Given this list of marker genes MLXIPL, GTF2IRD1, TMEM270, METTL27, RFC2, LDLRAP1 (low density lipoprotein receptor adaptor protein 1), RRAS2, GTF2I, LTBP1, FKBP6, ABCG8, FBLN5, BUD23 (BUD23 rRNA methyltransferase and ribosome maturation factor), EIF4H, STX1A, NCF1, LDLR, VPS37D, ELN, DOCK7 (NCBI Gene Id 85440), LIMK1, TBL2, CLIP2, ABCG5, PCSK9, BAZ1B, EFEMP2, APOB, GTF2IRD2, DNAJC30, here is a description of the gene set: studied in species Homo sapiens A pathological narrowing in the region above the aortic valve associated with restricted left ventricular outflow. Supravalvular aortic stenosis Human Gene Set: HP_SUPRAVALVULAR_AORTIC_STENOSIS